Given this list of marker genes GATA1 (NCBI Gene Id 2623), THOC5, HSCB, GATA2, PBX1, STK4, KMT2A, KDR, TAL1, SH2B3, GATA3, ATF4, KIT, HIF1A, VEGFA, ZFPM1, CCDC134, STK3, KITLG (NCBI Gene Id 780897), IL3, TPO, TGFBR2, MED1, FLT3LG, here is a description of the gene set: studied in species Homo sapiens Human Gene Set: GOBP_EMBRYONIC_HEMOPOIESIS The stages of blood cell formation that take place within the embryo.